Given this list of marker genes KIAA0319L, CA2, CLCN7, CXCL12, GPX2, GREM2, SOCS5, BRAP, ELF4, AKR1B1, PLCD1, AUH, ENPP1, SIAH1, FLG, PAK4, ZBTB20, HBB, ADGRL1, NEUROD6, PKD1, AGRN, S100A14, MMP12, TMEM266, SDF4, PACS1, BSDC1, TMED8, NMUR1, WT1, PSAP, NAP1L2, NREP, COL11A1, MX2, ITPK1, CHRNE, SLC7A11, AKR1C4, TGFB3, TLN1, RBM4B, ACSM2A, NR1D2, ZRANB1, TRAFD1, SH3GL1, AKIRIN1, ULK2, LDAF1, CLEC4F, CTNNAL1, S100A3, CAMK2B, TANC1, POLG2 (DNA polymerase gamma 2, accessory subunit), DTX1 (NCBI Gene Id 1840), NTRK3, GRIK1, GRINA, DKK3, ZNF600, SRXN1 (sulfiredoxin 1), RAB33B, HOMER2, KIT, SLCO3A1, EFNB2, USP2, GNGT2, SPPL2B, HLA-DOB, JARID2, PRXL2A, PHC1, MAPK8IP3, BDKRB1, TUBB4A, IRS2, MSL2, GBF1, STOM, CTNNBIP1, PPARGC1A, VPS37B, KIF3C, MME, ANKS3, MTMR10, SLC27A1, PRMT5, COL14A1, AQP1, DDA1, HIPK2, PNOC, FRAT1, ASB6, ICMT, TNNC2 (NCBI Gene Id 7125), HSPA1A, COQ10A, DIAPH2, DNTT, SLC12A7, TPT1, ABCC5, TCF20, PDE1B, PI4K2A, LENG8, KCNQ1, SOCS3, STAT5A, ZPBP (NCBI Gene Id 91091), METTL17, PLEKHA5, CXCR2, TLE4 (NCBI Gene Id 7091), PDE4B, RETN, BRWD3, KCNAB1, BLCAP, MFGE8, CANT1, MAP4K3, C22orf39, MOS, ERCC2, NGEF, DAO, KLF2, RO60, ACKR3, JUN, GML, IL27RA, RAB3A, SORL1, CACNA1C, BPIFA2, PCSK6, USP18, RFLNB, AXIN1, GZMA, IRF9, SH3GL2, FOS, TRIM13, APP (amyloid beta precursor protein), ARSA, ST6GALNAC3, ALPL, IDUA, ABCG1, TLR7, IGFBP4, CCNB1IP1, NEDD4L, GALNT10, GSTM1, CLTB, MYO5B, RPS6KA2 (ribosomal protein S6 kinase A2), PEA15, PHF1, CNGA2, SLC39A4, SEMA4F, EEF1A2, TNFAIP3, GABBR1, BCL3, ADCY6, EBF2, NOTCH3, GCSAM, FAM241A, CASQ1, ABCA1, GATA1, AP1B1, ITGAE, CD7, IRF7, FOLR2, CNTN3, SOX2, DIAPH1, NQO1, DENND2B, F7, CD14, BNC1, CWC22, here is a description of the gene set: from publication Agarwal P, Raghavan A, Nandiwada SL, Curtsinger JM, Bohjanen PR, Mueller DL, Mescher MF (PMID 19592655) Differentiation of naive CD8 T cells into cytotoxic effector cells requires three distinct signals- antigen (signal 1), costimulation -B7-1 (signal 2) and cytokine, either interleukin-12 or interferon-a/b (signal 3). Interaction of naive CD8 T cells with antigen and B7-1 programs cell division and proliferation whereas the presence of cytokines- IL-12 or IFNa/b promote survival, differentiation and memory establishment. In the absence of signal 3, the cells interacting with antigen/B7-1 undergo tolerance induction. The objective of this study was to elucidate the mechanisms how the provision of signal 3 promotes differentiation and averts tolerance induction in CD8 T cells. Trichostatin A is a pharmacological agent that inhibits histone deacetylase activity, hence regulating chromatin structure and gene expression and differentiation in many cell types. Gene signature profiles of IL-12, IFNa/b and trichostatin A stimulated cells were compared to elucidate the molecular mechanisms of gene regulation. Oligonucleotide microarray analysis is carried out to determine the extent and molecular nature of the CD8 T cell differentiation program induced by IL-12 or IFNa/b in concert with antigen and B7-1 signal. Genes up-regulated in comparison of CD8 T cells at 0 h versus those at 48 h. Human Gene Set: GSE15930_NAIVE_VS_48H_IN_VITRO_STIM_CD8_TCELL_UP species: Homo sapiens